The following is a description of a gene set: Genes up-regulated in liver samples of liver-specific knockout of HNF4A. from publication Ohguchi H, Tanaka T, Uchida A, Magoori K, Kudo H, Kim I, Daigo K, Sakakibara I, Okamura M, Harigae H, Sasaki T, Osborne TF, Gonzalez FJ, Hamakubo T, Kodama T, Sakai J (PMID 18426912) Human Gene Set: OHGUCHI_LIVER_HNF4A_TARGETS_UP Type 1 iodothyronine deiodinase (Dio1), a selenoenzyme catalyzing the bioactivation of thyroid hormone, is highly expressed in the liver. Dio1 mRNA and enzyme activity levels are markedly reduced in the livers of hepatocyte nuclear factor 4alpha (HNF4alpha)-null mice, thus accounting for its liver-specific expression. Consistent with this deficiency, serum T4 and rT3 concentrations are elevated in these mice compared with those in HNF4alpha-floxed control littermates; however, serum T3 levels are unchanged. Promoter analysis of the mouse Dio1 gene demonstrated that HNF4alpha plays a key role in the transactivation of the mouse Dio1 gene. Deletion and substitution mutation analyses demonstrated that a proximal HNF4alpha site (direct repeat 1; HNF4alpha-RE) is crucial for transactivation of the mouse Dio1 gene by HNF4alpha. Mouse Dio1 is also stimulated by thyroid hormone signaling, but a direct role for thyroid hormone receptor action has not been reported. We also showed that thyroid hormone-inducible Krüppel-like factor 9 (KLF9) stimulates the mouse Dio1 promoter very efficiently through two CACCC sequences that are located on either side of HNF4alpha-RE. Furthermore, KLF9 functions together with HNF4alpha and GATA4 to synergistically activate the mouse Dio1 promoter, suggesting that Dio1 is regulated by thyroid hormone in the mouse through an indirect mechanism requiring prior KLF9 induction. In addition, we showed that physical interactions between the C-terminal zinc finger domain (Cf) of GATA4 and activation function 2 of HNF4alpha and between the basic domain adjacent to Cf of GATA4 and a C-terminal domain of KLF9 are both required for this synergistic response. Taken together, these results suggest that HNF4alpha regulates thyroid hormone homeostasis through transcriptional regulation of the mouse Dio1 gene with GATA4 and KLF9. species: Mus musculus, and this is the list of marker genes: GSN, SERPINA7, REN, PCP4L1, RAB27A, ELOVL7, ACOT2, USP18, DRAM1, SLC27A1, CPT1B, ACOT1 (NCBI Gene Id 641371), IFI44, CYP39A1 (cytochrome P450 family 39 subfamily A member 1), PROM1, PDK4, RAD51B, PSAT1, HAO2, HSPA2, LYSMD2, GADD45B, TXNIP, SLC25A4, CA3, LEPR, SMPX, IL1RN, SLC2A4, CD36 (NCBI Gene Id 948), SULT1E1, QPCT, VLDLR, ELAPOR1, SULT2A1, ANXA13, RCAN2, SLC16A7, ABCB1, FMO3, CTSE, ABCD2, SLC22A9, DDR1, NRG4, CYP2B6, GSTM5, EMP2, DEFB1, SLC44A3